The following is a description of a gene set: from publication Yevshin I, Sharipov R, Kolmykov S, Kondrakhin Y, Kolpakov F (PMID 30445619) Human Gene Set: HOXA1_TARGET_GENES studied in species Homo sapiens Genes containing one or more binding sites for (HOXA1) in their promoter regions (TSS -1000,+100 bp) as identified by GTRD version 20.06 ChIP-seq harmonization., and this is the list of marker genes: RRS1-DT, SNORD84, LATS1, IER3-AS1, GATC, PANK2-AS1, METTL26, COP1, ABCG2, COX17, LACTB2-AS1, CLRN3 (clarin 3), SRI, MLH3, MRM3, ZNF106 (NCBI Gene Id 64397), STXBP3, LSM5, ID2-AS1, CCT7, PACRGL, WASF2, CCNI, SNORA21, DHX29, BNIP2, MRPS27, MIR3912, SLC39A1 (NCBI Gene Id 96436), SNAPC5, LINC01347, MROH7-TTC4, DXO, HS3ST3B1 (NCBI Gene Id 9953), NKTR, LRRC59, TSN, FAM228B, SRSF5, GCC1, NDUFA12 (NCBI Gene Id 55967), ZSCAN5A, UBE2B, POLD3, GBF1, MED4, SNORD15A, IK, DNAH6, ZNF692, CENPBD2P, VTI1A, NKAPP1, ANLN, TRMT10C, C4orf36, NCSTN, SEC24D, MAP3K11, CDK11B, ARL6IP6, WDR35-DT, ZNF888-AS1, PUS1, ZNF425, EXOSC9, GSK3B, CHP1, SELENOI, SLC35A1, NELFE, RBM42, CDKL3, PDSS2, PHLDA1-DT, CTNNBL1, PIGO-AS1, SLC38A2, ID2, ETF1, RSU1, RPL28, DHRS1, SDHA, ZFAND2A, NOL10, DDX39B-AS1, POLR3F, PTRH1, KIAA0825, TM9SF4, ATG14, CDK5RAP1, BECN1, PPM1A, RANBP3, ZNF26, SPG11, COX19, C2orf49 (NCBI Gene Id 79074), TBC1D19, WDR75, RNF141, ECSIT, NAGA, PPP1R12B, ANKRA2, CYSRT1, RPS28, SAC3D1, FLJ30679, COMMD1, TCAIM, KCTD9, CKMT2-AS1, PHF20L1, METTL14-DT (NCBI Gene Id 101929741), RPS29, SRRM5, NAPA-AS1, LINC00923 (long intergenic non-protein coding RNA 923), PGS1, SSB, PSMB7, GYS1, UBE2D3, DDX39B, TAF11, GINS1, FNIP1, CD320, TXLNG, CCDC12 (NCBI Gene Id 151903), PSMA2, SF3B5, KNL1, ROPN1L-AS1, CDKN2D, ERCC8, METTL14, ADNP, GPAM, F2RL1, RPS6, SLC39A7, SKIC8, NXF1, LRRC57, HOMER1, EEF1A1, NDUFAF5 (NCBI Gene Id 79133), RAB14, RABGAP1L-DT, PPIL4, ESPL1, HDAC6, SUPT7L, CDCA8, ZNF133, VPS18, TBCB, ERLIN2, MALSU1, DST, SKIC2, RANGAP1, RNF213-AS1, TMEM11, TMEM11-DT, TARS2, CLN3, PSMD8, EMC3-AS1, RPL15, IFT172, GOLGA1, CRIPT, MAN1B1, DNAJB12, PKNOX1 (NCBI Gene Id 5316), MIR5687, NDUFC2, RN7SL181P, WARS2-AS1, CTDP1, TMEM79, SMARCA4, SLC9A3R1-AS1, FADD, IFT70A, ATG5, RPS3, SIRT2, DENR, ACTR8, ANKS1A, RPPH1, CCT6B, UBE2C, AREL1, BRMS1, ZNF821, COX20, CHD1, NRDC, COPS8-DT, SAMD4B, TBCK, UBE2I, SEPTIN7P2, EXD1, POGLUT1, PCLAF (PCNA clamp associated factor), MOK, NSUN2, PRKRIP1, DDX6, FDXACB1, NACA, ENDOV, SAAL1, MYPOP, MIR4320, FXR2, FAM169A-AS1, ERCC3, LINC00111, ZMPSTE24-DT, ZNF584, NEDD4L, RPL13P5, SYAP1, FLAD1, TMEM170A, WDR89, MRPL19, ADAMTS7P4, ILF2, MAP2K3, RBBP5, TOMM22 (translocase of outer mitochondrial membrane 22), KIF2A, COP1-DT, AHI1, CERS5, MIR4453HG, MALINC1, ANKRD17-DT, VCF1, NIPA1, EIF3B, MYO10, SRA1, CWC25, CCND2, PATL1-DT, PGBD4, DCUN1D4, ALG10B, RRP15, ATG101, PTPN11, C1orf226, DNAH2, PSMB9, INO80E, PINX1, RNF38, RAD18, DCDC1, TOM1L2, RAD23B, TIPARP, PCCB, LIPT2-AS1, SEPTIN7P14, GTF2IP20, GUSBP11, SRP68, MIR3913-1, TMEM175 (transmembrane protein 175), SETDB1, THRAP3 (thyroid hormone receptor associated protein 3), LINC02960, LRRC40, ARL1, GOSR2, INTS9, METTL3, TRIM47, TBRG4, PABPN1, PRCC, NCDN, ING4, SLC27A5, ADGRE5, FAF1, AP5Z1, NMT1, SLPI, FAM222B, CCNT2, HMGCR, GGCX, NOB1, TMEM115, TMEM52, HSPE1-MOB4, MTMR11, CEMP1, ZNF341-AS1, MAGOH-DT, POLR2I, CANX, SPAST (spastin), MRPS21, ZNF805, DCAKD, SNAP23, B3GALNT2, STYK1, SLC25A53 (solute carrier family 25 member 53), FAM151B-DT, HIRIP3, KHSRP, KLC2-AS2, TM4SF4, LTO1, AKTIP, CACUL1, MORN4, ALDH3A1, OTUD6B, CATSPERD, RALBP1, HIGD2B, SIRT6, RAB11A, RFT1, MIR5087, TTC16, CLP1, LINC01623, EIF1AY, MRPL45, FAM98A, CHD1-DT, MIR5091, VPS51, UQCRC2, ATP5MG, ZFAND3, PTPN21, CIAO2A, OPA1 (OPA1 mitochondrial dynamin like GTPase), MTREX, PIH1D1, ZNF3, MMADHC-DT, VTI1B, RPL24, RN7SL832P, BOLA1, MED18, TAS2R14, SCFD1, ANKRD17, MAP3K13, KCTD2, WDR18, SEPTIN2, ZNF581, PHF12, PDCD6IP, RAB27A, LTV1, MAIP1, KBTBD4, HYCC1, PSMC5, ZNF589, TTC14-DT, CRYZL1, TXLNA, PPAN-P2RY11, LRRC27, HAUS5, RPL23, SNF8, RECQL5, HEXIM2, SFN, NUP42 (nucleoporin 42), STEEP1, DAB1, UBN2, STAT4-AS1, TRAF4, SNX8, HAUS2, GPRC5D-AS1, GPALPP1, FRS2, LAMTOR5, HAUS5-DT, RNVU1-21, HSPB6, LRRC1, NSUN4, FBXO8, TAF13, MIS18A, RANBP3-DT, ADGRF3, DUT, KIF9, TK2, HUWE1, BBS4, RABGAP1L, COPS8, FAF2, REEP4, CKLF-CMTM1, CEP44, GUCD1 (NCBI Gene Id 83606), CAAP1, KLHL18, ANKRD24 (NCBI Gene Id 170961), ATRIP, SEC62, RBM12, ACAT2, PAIP1, DMRT2, NFKBIB, RALGAPA2, ING1, C1orf21, NAPB, DMAP1, ENPP3, CCDC150, FAM220A, TBCCD1, AP1G1 (adaptor related protein complex 1 subunit gamma 1, NCBI Gene Id 164), ST13, ALDH3A2, MEAK7, TRIP4, CCDC90B, C7orf50, TNPO2, PARS2, UQCR11, PROSER3, KATNBL1, CAPZA2, N6AMT1, FUZ, PINX1-DT, GTF2IP12, ZNF830, TSPYL1, ZNF200, SLF1, COX7C, YTHDF3-DT (YTHDF3 divergent transcript), DNAJC24, PCBP1, PCBP1-AS1, MAN2A1-DT, NUFIP1, ZDHHC12-DT, ZNF692-DT, CCNH, SPTLC1, SLC25A16, GSK3B-DT, PHB2 (prohibitin 2), XAB2, RTCA, ADAT1, AIRIM, ZFYVE26, VPS35L, TYK2, NUBP2, SPOUT1, TDP2, PDE4D, ZNF217, ATP13A4, VAMP8, RNF216, CCNT2-AS1, NAE1, LINC02651, CNTD1, MOCS2, CMTR1, PARP9, GPATCH8, MRPL2, FLOT1, NBAS, MRPL49, PIPOX, GTF2H3, TOP1, STK19, CHCHD3, CCDC191, LUC7L2, ARFIP2, TMEM106B, PUS1-AS1, AGPAT5, EMG1, FDXR, NAT10, ZNF169, MORF4L2-AS1, THAP7, ENSA, APTX (NCBI Gene Id 94135), EIF2S2, PHB1, ZNF14, UPP1, KIFBP, MEST, MET, NDUFC2-KCTD14, PPAN, CEBPZ, ACOT13, GLOD4, SMG5, CIC, HIGD1AP5, ZNRD2, METTL25, SPRY1, SYNGR4 (NCBI Gene Id 23546), WDR37, CIDECP1 (NCBI Gene Id 152302), MMUT, CKS1B, PRKCI, DZANK1 (double zinc ribbon and ankyrin repeat domains 1), ADPGK, TMEM14A, AFF1, RNU1-117P, SLC4A1AP, MIRLET7IHG, GPATCH4, SNRPD3, RSBN1, ZAR1L, MTG1, RLF, TP53BP1, LINC03014, LINC00857, KITLG, SEMA4B, TRIAP1, POLG, GTF2H1, ALDH18A1, SECISBP2, MAGOHB, SEC11C, WDR35, DTX3L (deltex E3 ubiquitin ligase 3L), ZNF79, MMADHC, ZDHHC12, RHBDD1 (NCBI Gene Id 84236), ZFAND2A-DT, S100A16, GORASP2, TM4SF1-AS1, MAN2A1, EDEM2, MAPKAP1, YY1AP1, LGR5, EPS8, HARS2, NUBPL-DT, DNAJC16, MTNAP1, TRUB2, LARP1, MOCS2-DT (NCBI Gene Id 257396), TAP1, GFM2, TIMM44, CXXC1, HSPE1, CD72, SRSF9, LINC03011, SEPTIN7P13, MSRB1, CDK2AP2, NXT1, ABHD16A, CCDC90B-AS1, FBXO38-DT, EMC7, ZNF721, PLEKHA8P1, ZNF580, ASNSD1 (asparagine synthetase domain containing 1), SAFB2, PPP2R5B, ZNF302, SRSF6, TAF12, TRPT1 (NCBI Gene Id 93089), HSPA13, ARL6, STEAP2, FANCL, ALDH1A2 (NCBI Gene Id 8854), ASXL1, STAT3, MIR3677HG, IFT20, TLDC2, PSMF1, CENPJ, TPCN1, SYT8, LINC00513 (long intergenic non-protein coding RNA 513), PIMREG, IRGQ, TSR1, POLG-DT, DNAJB11, NDUFA7, XPNPEP3, RAPGEF6, SPSB3, IFRD1, TFIP11-DT, SPATS2, NEAT1, FBXL18, REXO5, RESF1, SLC26A2, TUBD1, CENPH, CFAP68, ITSN1, EPHA2-AS1, MAN1B1-DT, BLOC1S4, LINC01431, E2F6, SLC52A3, AHI1-DT, RPA2, ENO1, ANKRD26, KLC4, COQ4, THAP11, PURA, UTP15, UBAP1, UGP2, TYW5, ALKBH2, CFAP206, ZNF426-DT, RAD23A (RAD23 homolog A, nucleotide excision repair protein), IQCN, ERG28, OXNAD1, RAVER1, REXO4, NKIRAS1, BCL2L2-PABPN1, CFAP69, EHD1, CPNE1, TUBGCP6, CLDN12, TIPARP-AS1, SPINT1, RXRB, CBX1, CYP4F12, CTTN-DT, PRKAR1A, CTTNBP2NL, ANO6, PATL1, ESF1, CHORDC1, MORF4L2, PIGF, NBPF3, WDR5B, MAP3K5, SHC1, SRGAP3, ASMTL, CENPO, NOP56, SHPRH, NGDN, MKS1, MTHFSD, MICAL3, NR4A1, ZSCAN32, ACAT1, LRRC23, SMG9, TMEM214, PDXDC1, PEX12, EIF3M, ANAPC16, NDUFV1-DT, DMXL2, PIGG (NCBI Gene Id 54872), PRKG2-AS1, IFNAR1, PMS2, STAT1, ZNF324, ZFAND3-DT, UBXN4, MARCHF3, AP3D1, POP4, H4C1, XPC, EHHADH, RPSA, TMEM198B, THUMPD1, UQCRC1, ACP1, MIR4727, ACSL1, LMNB1-DT, FHL1P1, PDCD7, VCPKMT, MIR4512 (NCBI Gene Id 100616149), TSEN2, LMNB1, KRBA2, PNLIPRP1, RN7SL1, BRCA2, METTL25B, ARAP1, ZNF317, SEC61A1, EID2B, AP1M1, RNU6-92P, ATAD3A, THAP7-AS1, BCL2L2, TNPO1, GTF2IP13, PRPF6, RLIG1, NDUFS3, GLRX5, SEC23B, RANBP1, TEDC1, MAGOH, HDGF, BTBD19, SERINC1, CCDC15, DENND6B, SAP30BP, KLHL7, TRAM1, ENSG00000254718, BCKDHB, SUPT3H, ACOX3, ABCF2, CPSF4, ZNF174, IST1, PPP4R3B, ASAH2B, PRH1, DAP3, RBM6, ZC3H15, RTCA-AS1, CACTIN, VPS52, FCSK (NCBI Gene Id 197258), PUM3, PDCD2L, WDR74, HSPD1, HSD17B1-AS1, PCNX3, HAX1 (NCBI Gene Id 10456), APAF1, SMG8, CCDC127, IFT122, CD55, FBXO38, EXOSC10-AS1, COA3, TMEM126A, MATCAP2, ST20-MTHFS (NCBI Gene Id 100528021), SDCBP2, ACLY, TNFAIP1, SAP18, TRIB1, C10orf88, CCDC59, CTTN, CAPZA1, ADAP1, SLC25A37, AIMP1, PABIR3, RPS6KA1, HP1BP3, PIGB (phosphatidylinositol glycan anchor biosynthesis class B), ZNF846, CATIP-AS1, KLHL28 (NCBI Gene Id 54813), KLHDC4, ALG10, ZNHIT2, ZNF23, GPRC5C, SNX10-AS1, C12orf76, ISY1, NUP153, PANK2, RBM25, USP48 (ubiquitin specific peptidase 48), NARS1, UXT, TMEM203, IDH3B, CREB3L4, EIF3F, CDC7, SNX1, GAK, ZSCAN5A-AS1, TTC14, TNFSF10, IRAG1-AS1, MROH7, TDG, SUPT16H, MIS12 (NCBI Gene Id 79003), RPL5 (ribosomal protein L5), KCTD16, TIMM10B, MCPH1-AS1, SFSWAP, DDX55, WARS2, MIR4258, SH3RF2, NFX1, ZNF497-AS1, CENPT, VRK2, METTL1, CDC73, KLHL7-DT (KLHL7 divergent transcript), ACP6, SF3A2, GPR107, ACTR2, CALU, CNOT1, CFDP1, ZNF497, ATP6V0E1, G3BP2, MTIF2 (mitochondrial translational initiation factor 2), SLC11A2, CCDC163, SCAF1 (NCBI Gene Id 58506), ZDHHC6, GZF1, HSD17B4, CHMP7, DIAPH1, TMUB1, LNPEP, TUBGCP3, SGSM2, PRORSD1P, RFX2, PFAS, TMEM222, DCTPP1, HDLBP, STK40, TM4SF1, PKIB, ASCC1, PRMT3 (protein arginine methyltransferase 3), C9orf78, EEF1AKMT1, LINC02366, FCF1, NOP9, UBE2D3-AS1, CASP9, FIGNL1, PIGBOS1, IPO11, GPN2, RABL3, IFRD2, TAF12-DT, DPH3, PET100, H2AZ2-DT, EWSAT1, USP38, TOGARAM1, LDHA, PHLDA1, PSTK, NFIA-AS1, GNS, CENPQ, QTRT2, EFNA1, CKLF, CDKN2C, CARD8, DNAJC14, NEK9, C10orf88B, TOMM22-DT (NCBI Gene Id 124905117), BOD1, GFM1, LINC03015, THEM4, NDC80, LONP1, RPS8 (ribosomal protein S8), DUS2, MZT2B, ABHD10, ZNF576, FBXL9P, CENPW, RPS6KB2, TOM1, MRPS9, FBXW9 (NCBI Gene Id 84261), STEAP2-AS1, TTC1, FAM13A, UQCC4, PIGO, STK32C, GTF2E1, HMBOX1, COPA, TMEM208, HPS5, TMEM216, IRAK1BP1, C1D, RPS15A, NDUFA2, RPL13, DHDDS, SRD5A1, MIF, PLEKHJ1, ATG4B, UBE4A (ubiquitination factor E4A), SH3YL1, PICK1, ALAD (NCBI Gene Id 210), TNPO1-DT, SNORD55, MRPL32, CCT4, NSMCE3, COQ6, IQCD, NTAN1, ERI2, SMPD4, ADRM1, PRPF40A, ZMPSTE24, PARP2, XRCC1, TM9SF2 (transmembrane 9 superfamily member 2), HARS1, SLC25A44, CCDC86, GTPBP10, MAN2C1, FANCD2 (NCBI Gene Id 2177), YWHAQ, TTLL5, FTSJ3, STARD10, PTPRO (NCBI Gene Id 5800), MRPS34, NOL7, FAAP100, YIPF5, MCM6, CARS2, C1orf74, SPATA2, FAU, ZNF426, MTG2, SPEF1, ATG16L1, SPATA7, DRC3, MRFAP1L2, SNORD46, YTHDF3, ZCCHC9, NUDT22, MRPS17, NUBPL, GOSR2-DT, ATP9B, EIF2B1 (eukaryotic translation initiation factor 2B subunit alpha), TMED10, IKBIP, BET1, DSTYK, CDK13, OMA1, ADHFE1, BOD1L1, CCDC7, MCRIP2, HNRNPL, NPDC1, TLL2, MGST2, RC3H1, CFAP410, WSB2, NPM1 (nucleophosmin 1), CCT2, GNAI3, MRPL24, SLC38A2-AS1, RPS18, FZD1, EEF1A1P23, ZNF184, DSE, CDCA2, PTCD1, SESN1, UTP25, DYNLT4, MBD4, MYO15B, MRTFA, ZNF337-AS1, MVK, ARMC5, FBXW7, RNASE11, ERCC2, RNA5SP473, MED23, RPN1, ZNF444, DCAF1, ITPA, KIF3A, TMEM39A, PNISR, CCDC174, NDUFAF7, RNPS1, NDUFV1, GAS2L3, CEP57L1, PYCR2, DYM, DERL2 (NCBI Gene Id 95558), FAM24B, TCF25, ROPN1L, SPINT1-AS1, IFT27, VAPA, MRPL36, METTL4, HCG27, MFN2, EMC3, KPTN, CHMP4B, ISY1-RAB43 (NCBI Gene Id 100534599), LINC02482, THAP4, SNRPB2, SLC9A6, MAP4, THUMPD3, ENSG00000260830, NRIP1, RPL21, RHOA, RAB11FIP3, DLEU2 (deleted in lymphocytic leukemia 2), RPS6KB1, TMEM230, KDM4B, CDK11A, NUP214, TMEM131, RAB5IF (RAB5 interacting factor), SRSF11, NPRL3, PROCR, TRAPPC14, NEURL4, SNORD68, NAGK, MED27, ARV1, SLC25A3, CCAR2, PRR4, BDP1, IARS1, AIMP2, EEF1AKMT3, NDOR1, CDON (cell adhesion associated, oncogene regulated), SIX5, PARP12, TTC13, RMDN3, ZNHIT6, N4BP2L2, EMC4, POM121, IGSF9, CEP20, RAB1B, ADSL, TFIP11, RNF186-AS1, LTN1, KCNK5, SLCO4A1, CDK8, USP20, TRMT61B, ST7L, LGALSL, IDH3B-DT, GTF2IRD1P1, FBXO4 (NCBI Gene Id 55087, F-box protein 4), DYNC2I1, WDR5B-DT, KIAA0319L (KIAA0319 like), SLC25A48, TRMT2A, NSA2, PTRHD1, TBL3, LAMTOR5-AS1, CCNT1, GPKOW, TUBB, MMACHC, MRPL38 (mitochondrial ribosomal protein L38), SNHG10, RUVBL2, MTFR2, YJU2B, RPL39P40, SAFB, TMEM143, OTUD6B-AS1, NUP155, PSME3, XPO1, CISD1, UQCC6, ZNF614, ISG20L2, HEXIM2-AS1, RNU7-27P, LINC02920